Given this list of marker genes FOXN4, NKX2-2 (NK2 homeobox 2), DMRT3, SOX1, GLI3, SUFU, LMO4, ASCL1, DLL4, DBX1, GATA2, LHX3, GLI2, here is a description of the gene set: species: Homo sapiens The process in which neuroepithelial cells in the neural tube acquire specialized structural and/or functional features of ventral spinal cord interneurons. Ventral spinal cord interneurons are cells located in the ventral portion of the spinal cord that transmit signals between sensory and motor neurons and are required for reflexive responses. Differentiation includes the processes involved in commitment of a cell to a specific fate. Human Gene Set: GOBP_VENTRAL_SPINAL_CORD_INTERNEURON_DIFFERENTIATION